Given this list of marker genes RRP1B, SNX10, PRDM1, PFKP, ITGB1, ATP2B4 (NCBI Gene Id 54594), CCDC50, KLRC3, ELL2, TASL, BHLHE40, CD38 (CD38 molecule), DKKL1, ARL4C, CIPC, IFNAR2, CHIC1, CAPN11, PPIL2, RAD50, PRF1, ITGA4, RGS1, TTC7B, IL18RAP, LAIR1, CDKN2AIPNL, MLKL, CXCR3, GIMAP4, HDHD5, RPA2, SOAT2, DPM3, CCL5, VIM, KLRC1, GGH, EPSTI1, S100A4, POGLUT2, MFSD6, H2AZ1, GVINP1, DSTN, LPIN2, MYO5A, RORA, ARHGAP18, IL2RA, IFNGR1, ATXN1, FCGR2B, ZDHHC2, AP1G2, SOS2, ASNS, NKG7, PPP3CC, COMMD3, IL18R1, LGALS1, ITGAX, UBA6, CST7 (cystatin F), F2RL2, GPHN, ATXN2L, AQP9, MYO1F, ABHD5 (NCBI Gene Id 51099), SLC52A3, MYADM, KLRC2, PTPN22, HMGB2, TNFSF8, ANXA1, POLK, PPP1R35, DIPK2A, CASP4, WWP1, DMRTA1, ANXA2, CD44, GSAP, RUNX2 (RUNX family transcription factor 2), OSBPL3, FRRS1, BCL2L1 (BCL2 like 1), LRRK1, NRP1, CASP1, LDAF1, FIBP, TTC39C, GRAMD1B, PCGF2, SLAMF7, CEP70, EEA1, OXSM, GRINA, EOMES, NT5E, GALNT3, HCST, S100A6, CYFIP2, ARHGAP5, RDM1, TTC39B, SMPDL3B, CYRIA, STARD10, ADAM19, CHPT1, GZMK, HLA-B, CTSD, ENTPD1, GNPTAB, CNOT6L, ZFAND4, UNC5A, TMEM65, CYRIB, PDE2A, CALM2, TNFRSF1B, IL15, ITGAL, PRKAR2A, IFNG, CCR2, PTPN2, ITGA1, HOPX, MYO3B, LPIN1, TBX21, IL12RB2 (interleukin 12 receptor subunit beta 2), PTPRJ, ARL4D, DAPK2, DOCK5, PTGER4, TNFSF14, PGLYRP1, PIK3R5, CTSW, PLEKHM3, ABHD14B, ZEB2, BSPRY, AHNAK, CXCR6, ERLIN1, S1PR5, L1CAM, KCNJ8, KLRK1, TMBIM4, KATNB1, IL7R, SAMD3, ID2, RNF216, ATP6V0D2, IMPACT (NCBI Gene Id 55364), GZMM, ATP2B1, PTPN13, CD226, PARP8, EBPL, CDH1, SYTL2, here is a description of the gene set: species: Homo sapiens Human Gene Set: GSE2935_UV_INACTIVATED_VS_LIVE_SENDAI_VIRUS_INF_MACROPHAGE_DN Thus, mouse macrophage cultures were established from PBMCs isolated from wild-type control mice and were inoculated with SeV (Sendai virus) or UV-SeV (UV-inactivated SeV). These microarrays were performed in concert with assays of CCL5 and CCR5 expression, viral replication, and cellular apoptosis. Initial experiments indicated that wild-type mouse macrophages inoculated with SeV exhibit induction of CCL5 mRNA to the highest level of any known mouse gene product, while mRNA levels for CCL5 receptors (CCR5 as well as CCR3 and CCR1) or alternative ligands for these receptors (CCL3 and CCL4) were relatively unchanged by viral infection. from publication Tyner JW, Uchida O, Kajiwara N, Kim EY, Patel AC, O'Sullivan MP, Walter MJ, Schwendener RA, Cook DN, Danoff TM, Holtzman MJ (PMID 16208318) Genes down-regulated in macrophages: control versus Sendai virus infection.